The following is a description of a gene set: Mouse Gene Set: GOCC_NUCLEAR_STRESS_GRANULE species: Mus musculus A dense aggregation in the nucleus composed of proteins and RNAs that appear when the cell is under stress., and this is the list of marker genes: Sympk, Pkp1, Hsf1 (heat shock factor 1), Tia1, Eif4a1, Rbfox1, Sumo1, Dhx9